The following is a description of a gene set: from publication Yevshin I, Sharipov R, Kolmykov S, Kondrakhin Y, Kolpakov F (PMID 30445619) Human Gene Set: DACH1_TARGET_GENES species: Homo sapiens Genes containing one or more binding sites for (DACH1) in their promoter regions (TSS -1000,+100 bp) as identified by GTRD version 20.06 ChIP-seq harmonization., and this is the list of marker genes: COMMD1, NHERF2 (NHERF family PDZ scaffold protein 2), SLC35B1, SS18L1, DLL3, ZFAND3, ZNF514, GYPA, ATP6V0A1, SLC36A1, SSR4, ASAH1-AS1, SNX24, RBM15B, ACTR3, GPN2, WHRN, PNKP, TSNAX, FRMD8, TJAP1, C8orf58, C10orf88, PDIA5, ASIC2, EOLA1, FANCD2, RBL1, PTGES2, ZNF778-DT, GOLT1B, BACH1, RBM3, ORMDL3, DDX39B, SKP1, WDTC1, ARHGEF10, PVALEF, CD63, ZNF18 (zinc finger protein 18), BMI1, PIEZO1, DDX42, PNO1, BBC3, NFIX, PROSER1, CHCT1, RAP2C, DYNC2I1, SAR1AP2, LIMD1, TENT5A, GOLGA5, ZNF696, PORCN, PCAT6, PPM1K-DT, ARF5, CLN8, EHMT1, PDE4A, APOOL, SQLE-DT, SETX, CFAP298-TCP10L, CLASP2, SMARCAD1, TAF9, EIF4H, C6orf52, ATP6V0D1-DT, NDUFAF6, PRPF40B, SOCS2-AS1 (SOCS2 antisense RNA 1), NECTIN1-DT, HDAC5, CBFA2T3, PPTC7, AFF4-DT, SLC46A3 (NCBI Gene Id 283537), FBXO5, DBNL, YPEL5, CSAD, SQSTM1, ATP6V1D, TSPAN12, P3R3URF, SNX29P2, U2SURP, WIPI1, TNPO1, PSMD1, POLR2J, RXYLT1, LINC02863, SPMIP2, PITPNM3, ZDHHC9, PRKCB, FARSB, HIPK3, CAAP1, ENSG00000187951, LCDR, CSF1R, EPM2AIP1, HJURP (NCBI Gene Id 55355), DDX46, SPG21, NXPH3, RPL24, RPH3A, SNORD101, RAD51AP1, PC, SYTL1 (synaptotagmin like 1), TK2, TRIP12, SLC25A13, NME7, PSMG2, RNF121, ESCO1, PSME4, TBCK (NCBI Gene Id 93627, TBC1 domain containing kinase), MDK, PIGX, GPI, EGLN1P1, MIR3681HG, NOC2LP1, ARFGAP3, NOSIP, COX7A2L, GTF2IP12, ZNF576, EBAG9, YJU2B, AMDHD2, CEP76, SPDYC, LINC01270, PIMREG, ZC3H7B, PARP12, FAM110A, ARHGEF18-AS1, PTPRF (protein tyrosine phosphatase receptor type F), LINC02882, UBTF, UBE2O, USP49, GUCY2EP, RNVU1-4, ACOX2, ABR, WDTC1-DT, CYP4F2, NUP85, RPA3, EHBP1L1, LMF1, TMEM9B, AK6, ALG14, HOXB3, DENND1C, LINC02777, HECTD3, MAPKAPK5-AS1, ZBTB32, TRIB3, OSCAR, TXNDC16 (NCBI Gene Id 57544), MOB4, NOC4L, XNDC1N, RPL35P5, STAT3, CAPRIN2, LINC00957, ARL8B, CHTF18, PLCXD1, STC2, LRR1, GBE1, CCT4, APOBEC3D, NUDT6, PARN, RAD17, MIGA1, FOSL1, EXOSC5, TYMS, CDC73, SNX18, MRM2, IL20RB, DNAJC28, BUD31, LRRC23 (NCBI Gene Id 10233), SNHG25, TNS1, AHI1, SPATA31B2P, OR10G6, TPT1-AS1, VGF, RPL23AP82, IFITM5, RHBDL1, ARL6IP5, ZKSCAN5, CUX1, UROD, STAT2, COL4A5, ATP5F1C, OSGEP, PEAK1, GFI1B, KDM4C, SLF1, RBBP5, RHOG, RECQL, TXN, ANK1 (NCBI Gene Id 286), VPS13C-DT, TMEM9B-AS1, RNF11, ARHGEF18, LINC00475, TUBAL3, DNAH7, UPK2, ZFAND3-DT, USP9X, CCDC91, SNX4, SLC2A1, BARHL1, BAIAP2 (BAR/IMD domain containing adaptor protein 2), ADAP1, MTMR4, SLC25A10, MIER3, NECTIN1, DCXR, DPH6, POU4F1, TP53RK-DT, KIN, CLDN12, GYPB, POLI, HAUS2, NBPF15, ABHD2 (NCBI Gene Id 654057), LRRC37A16P, FUBP3, RNA5SP21, MCPH1-DT, ACTB, FABP5P5, TFAP4, MIR1915HG, PTBP1, POLR3G, MRPL40, NCAPG2, POLR2G, SH3BGR, SOCS2, WDR81, ARAP1-AS1, GPR137C, LZTFL1, SNX19, MGST3, PYCR2, UBFD1, SNORD104, SHCBP1, LINC01619, CARHSP1, CDIN1, NGF-AS1, CD63-AS1, SGTA, CTCF-DT, C19orf48P, LINC01426, ENSG00000226087, MRRF, ZNF740, SQLE, IQCH, TRIB1, KBTBD11-OT1, ELL, NAGK, RN7SL473P, OR8G3P, STX7, ALS2, CLCN3, NIPSNAP3A, TBCD, NEGR1, TLE5, NHLRC3, MINCR, UBTD2, RPS29, RNU6-889P, FBXO36, C19orf38, DNAJC25-GNG10, RN7SKP249, CA14, EHD1 (NCBI Gene Id 10938), RANBP6, USP4, CEROX1 (NCBI Gene Id 115804232), PPIAP8 (NCBI Gene Id 5490), NIBAN3, HMGN2, RBL2, CRKL, LINC02523, PDE8A (phosphodiesterase 8A), SYT7, NFE2L2, ENSG00000233230, SCAND2P, ENSG00000233461, WNT1, ZNF641, BAHCC1, CYP2W1, VAT1, NISCH, SLC22A18, NVL, WNK2, RERE, RNU2-41P, PIN4, NDC1, LINC01094, MCRIP1, AGBL2, PLK3, ACVR1, LSM14B, PHB1P16, RABGEF1, ABCA7, ATP6V1G1, MYBPC2, ODC1, STAM-DT, C22orf15, SEMA6B, TNFAIP3, ACAD9, ERCC6, DNAH9, IRF2BPL, PSAP, STUM, DIPK1A, LINC02569, PES1, ACTR10, GGA3, CCDC88B, CCL26, CSTF2T, IQCG, TRAPPC2L, ID2, WDR7, XKR4-AS1, DEFB132, LINC00652, RNU6-901P, ETV2, ACAP3, PALB2, DDX51 (NCBI Gene Id 317781), VPS54, KRT8, SLC25A19, FN1, LINC02870, STAT1, MYO9B, CARHSP1-DT (CARHSP1 divergent transcript), DCAF5, SEC61B, GLUL, MAP2K1, MPDU1, TCF3, ZPR1, S100A2, USF2, COPS7A, DHODH, IDH3G, B3GAT3, KCTD7, TMEM87B, LINC02366, PRPSAP1, NAA38, SIX5, ZNF513, AIMP1, CDPF1P1, RN7SL832P, MIER1, WIZ, GTSF1, ZNF778 (zinc finger protein 778), SUV39H2-DT, CCNA2, HMG20A, BABAM2, MLXIPL (MLX interacting protein like), MYADM (NCBI Gene Id 91663), NOX5, TAFA2, GALE, AHCY, MTFR1, MARF1, BBS12, TBC1D10A (NCBI Gene Id 83874), SMTN, DDX39B-AS1, ZNF821, TP53INP1, ARNT, STAM2, INSR, RPUSD1, MINK1, RPS29P22, WDR37, TSPAN14, FSIP2LP, SLC38A5, TNRC18 (trinucleotide repeat containing 18), ATP5MG, WT1, BRSK2, UFSP2, TIPIN, BEND3P1, EIF2S1 (eukaryotic translation initiation factor 2 subunit alpha), CRAT, CEP63, MRPS5, PTPRS-AS1, RPL35A (ribosomal protein L35a), NSUN2, NEUROD4, DAZAP1, SIN3B, MIR3193, KBTBD2, FARP2 (FERM, ARH/RhoGEF and pleckstrin domain protein 2), TSC1, ADO, MTHFD1L, MECP2, GAN, PUSL1, HADHA, RAMP1, PDAP1, WDR45, PITX3, ZCCHC2, IRS3P, CCDC26, EZR-AS1, SNRNP40, DGAT1, RNF14, SRSF4, ENSG00000269155, MYBPHL, ZSWIM7, SEPTIN7P14, ERI2, COL4A6 (collagen type IV alpha 6 chain), NBR1, MYO7A, NR2C2, USP48, GOSR2, FUZ, SLFN11, ALG2, KMT2A, MEF2A, SOX8, ADGRE5, POLR3E, KRI1, RUSC1, ID2-AS1, PCLAF, SLC12A4, PSTK, DPH6-DT, TXNL1, COMP, MARK2, CFAP96, RAB18, ADNP, DDX31 (NCBI Gene Id 64794), EPOR, CNTNAP2, YARS1 (NCBI Gene Id 8565), CIAO3, LINC03099, MCOLN1, SRRM5, MICAL2, CIDECP1, ELF1, BTBD19, CLK1, BMS1, TAX1BP1-AS1, SMARCAD1-DT, COX5BP7, SKA1, GNG5B, ZNF23, PIK3C3, COASY, ZNF335, TLCD1, CD82 (NCBI Gene Id 8052), SSBP4, KCTD2, SPPL2A, SELENOW, DMKN, DNAAF10, RGCC (NCBI Gene Id 730127), RAB9A, CPEB4, ACIN1, LINC02733, NDRG1, ABCB10, RPL36AP48, CTSD, TPT1, CIC, CREM, EIF2S3, ERCC1, CLIC3, TRAPPC6B, IRGQ, CREB3L1, UPF2, PNPLA8, MIR155HG, TMEM9, CDK5, FARS2, CAPRIN1, ENSG00000253796, LINC01585, LINC00240, FERRY3, DHDDS, PLEKHG2, SMPD1, MEF2C, ELN, XPNPEP1, HAGH, DCTN5, UBE2F, LINC01278, AAGAB, GTF3C4, NBEAL1, FLCN, TEKT1, ZNHIT3, TCN2, MAPKAPK5, RWDD1 (RWD domain containing 1), SETDB2, REXO1, ABHD17C, MIR4690, GRK6, ATP5IF1, SUPV3L1, CDC25A, CASS4, SRD5A1, AP5S1, COL6A3, SVIL-AS1, ZNF554, ESRRA, RHBDF1 (rhomboid 5 homolog 1), ICE1, RAC2, INPPL1, SUV39H2, ARL4A, VSIG10L (NCBI Gene Id 147645), AFG2A, EEF1A1P5, MED13, ZNRF2, GATAD2A, TMEM258, LRRC37A5P, RNU6-800P, PPM1K, TMED1, SNORD48, HMBS, SVOP, CYP4F3, RHOBTB3 (Rho related BTB domain containing 3), PPIL4, FADS1, TAF13, SLC12A6, WBP4, MTND5P31, CEP19 (centrosomal protein 19), FAM187A, GALNS, MLH1, OR4G4P, CHCHD2P1, DHCR7, GOSR2-DT, ARF1P2 (NCBI Gene Id 100420012), ZNF396, SNHG32, DNAJB2, RFESD, EARS2, ENSG00000238390, S100PBP, RNF125, CAB39L, TSN, MIR4477A, FGF18, COTL1, TTLL7, PPA1, HSPA9 (NCBI Gene Id 91471), MAILR, ARHGAP4, PGM3, CYGB, MIR7155, FRMD4A, LSS, CHD9, PDXK (pyridoxal kinase), LGALS1, NDUFS4, AHCYL2, MTHFD2, TRPS1, HEMK1, KDM6B, HMGCL, PAK1IP1 (PAK1 interacting protein 1), TAF12, SMYD3, FZD1, GPD1L, KCP, EVI5, SRCIN1, BLCAP, ENSG00000259182 (NCBI Gene Id 124903565), GPX3, TRDMT1, GPAM, NYAP1, FAHD1, VMP1, MCPH1, TRGV7, ANAPC13, MYO1C, TOMM5, HES6, CHAC1, VSIG10L-AS1, ENSG00000212479, FAM219A, CMC2, ZNF2, NAT9, ASAH1, SNORA50C, MIDEAS, WT1-AS, CERS6, DGKG, H4C4, PRAMEF1 (NCBI Gene Id 93189), NKAIN1, CCDC186, PICALM, P3R3URF-PIK3R3, ARL15, ARAP1, MRPL11, VPS18, TOM1, HIVEP3, SMC2, CA1, DDX41, LARS2, MIR22HG, TPH2, CETN4P, IST1 (IST1 factor associated with ESCRT-III), SALRNA3, OGDH, ANO8, PEX7, RBM18, WDFY1, CHFR-DT, FAXDC2, WASHC4, MAF, SPANXN3, LINC02293, CTDSPL2, WAKMAR2, KCNH2, EOLA1-DT, AAR2, ANAPC1, SLC8A2, SMIM20, MYO15A, LINC02918, CCDC50, RPL31P43, ATG13, ATXN10, CLPTM1L, HADHB, NBN (nibrin), ENSG00000253986, CMKLR1, TM9SF1, PFDN4, RNU6-841P, VDAC2, ZSWIM8, PBX2, MBLAC2, RASSF6, MIR30B (NCBI Gene Id 407030), PHLDB1, SECISBP2L, REXO5, GYPE, UBE2V1P4, SEC13, GPBP1, IQUB, DNHD1, ADPGK, RNU6-992P, TTC19, ETV4, CRYBG2, IKZF4, MPG, TRAPPC13, COPRS, RABL2B, PPP2R5B, GALT, CDC25B, TMEM45A, MFAP3L, LANCL2, MARK2P5, TSNAX-DISC1, BAZ2A, FHL2, RAD9A (RAD9 checkpoint clamp component A), MRPL34, CHST11, SUDS3, RASA4, LINC02666, CLN8-AS1, SCUBE2, SYNRG, RANP5 (NCBI Gene Id 100129428), TJP3, FRYL, PNMT, IKBKG, LIG4, IGF1, CCNE2, PANX1, PTGES2-AS1, CYP4F8, MIR148A, HIF1A, ELOA, RPL13P5, HIRA, TRMT13, RIOK3, ARHGEF6, SDK2, GUCA1A, RNU7-124P, SMAD5, ZSCAN2-AS1, WASH3P, RPLP0P12, ZFYVE1, SUCLA2P2, ZNF799, RPL9P7 (NCBI Gene Id 6126), APOBEC3C, MCM3AP-AS1, CTNND2, SYT10, GUSBP2, TRIP4, SLF2, STX8, MDM2, RPSAP31, TP53RK, PARL, NBPF9, EEF1A1, NADK, SPEF1, ANKRD9, RN7SL480P, SC5D, CARS2, E2F2, ZMAT3, NDE1, NRBF2, DNAJC13, BMF, SUCLG1, SLCO1A2, TPRA1, OR4G3P, ALDH5A1, DNAJC25, BRWD1, KEAP1, CFAP298, TRADD, R3HDM2, OTULIN, NATD1, MTCO3P8, CALCOCO1, NUDT1, LINC01353, GTPBP3, LYRM4, PPP1CA, OTULIN-DT, RPS12, AP3D1, DNAI1 (dynein axonemal intermediate chain 1), CHFR, DHCR7-DT, TCP11L1, VPS13C, UBALD1, ZFAND1, AFF4 (NCBI Gene Id 27125), NDUFA4, EIF4ENIF1, LINC02846, SLC35E2A, STAT6, TP53INP2, ZNF451, MAFA, MRPL46, CACTIN, DTNBP1, MRPS7, GABARAPL1, SP7, IQSEC2, RPL21, MSLNL, NAPRT, BCKDHA, PTPA, SPAG7, ZNF529-AS1, EEF1A1-AS1, PYCR1, SH3BP1, CCDC83, VTI1B, BLZF1, POLR2E, TMEM104, ATXN1-AS1, DDHD2, MTO1, CFAP52, STK32C, LRRC47, SORBS2, RENBP (NCBI Gene Id 5973), TTC8, SCN9A, MYL4, KPNB1, ENSG00000232884, PDCD2, ODC1-DT, RASA4CP (RAS p21 protein activator 4C, pseudogene), CEP57, ATP6V1C1, POLR2M, LINC00661, CCDC103, ZNF366, SLC2A4RG, RBKS, STAM, USP32, APEX1 (apurinic/apyrimidinic endodeoxyribonuclease 1), ATP6V0D1, TRAK2, EFTUD2, TRIR, IPO13, RWDD2A, TXLNG, RNU6ATAC32P, TUSC2, DZANK1, RN7SL75P, KDM3A, BAG6, CYP2B7P, KYAT1, RPS17P1, MIR5698, TKFC, BZW1, AKAP8, FAR1-IT1, HMX3, GPRC5C, USP31, CLIC4, STON2 (NCBI Gene Id 85439), BDH1, MRPS11, POLR3F, HEATR3, DM1-AS, OR4G6P, LNC-LBCS, LNCTSI